Given this list of marker genes KCNK6, ELAVL1, ITGB2, ARAP2, COX17, PACSIN1, TARDBP, MIS18A, ORC2, PLAAT3, NCOA7, IL10RB, MCM5 (minichromosome maintenance complex component 5), LDLR, FAM98B, SLC4A7, SLFN12L, FASLG, SIMC1, TUBA1B, DUSP5, DYNLL2, PUS3 (NCBI Gene Id 83480), ATL3, IMPDH2, MED14 (NCBI Gene Id 9282), ACSL5, ITPR1, AR, TSPAN13, SERPINC1, BAZ1B, RCSD1, EGR3, FYN, RNF152, SNX9, PPP1R16B, MRPL15, POLE, HERC4, CYBA, ITK, TBC1D4, RPA2, IL6ST, TFRC, CSE1L, PHLDA1, RHOD (ras homolog family member D), ISOC1 (NCBI Gene Id 51015), EDC4, MND1, BEND3, RPIA, CSF2 (NCBI Gene Id 1437), OBI1, ARHGEF3, AGR3, TLK1, CD2AP, NEFH, EFHD2, PTER, CTSS, ARFGAP2, CRIM1, TCF20, TMEM131L, FAM111A, MINDY2, TESK2, MCM9, CDK1, TNFSF8, STARD4, SAMSN1, RAB34, NAA20, PENK, ERMP1, PTPRS, ADAM10, UBXN2A, PDCD4, DROSHA, IPO11, DTYMK, SMC6, MGAT4A, ZNF592, PLAGL1, POLR1F, NUCKS1, CENPA, PARP12, SLAMF6, ITIH5, PLXND1, SIK1, LANCL2, ACAT2, PTTG1, RFWD3, FOXK1, ATP11C, NAA50, QSER1, CD96 (CD96 molecule), MLH1, SLC23A2, ITGB1, NRP1, WDR75, WEE1, ZNF770, PLA1A, PSMB8, PHF14, RBBP7, HPS4, DAPL1, LIG1, EXO1, SEMA4C, ZSCAN21, SYTL2, ZNF280B, CDC20, LYPD6B, ST8SIA6, NCF1, PTS, SCIN, MSH6, KPNA2, CYC1, GAS2L3 (NCBI Gene Id 283431), TPST1, CD1D, FOXN3, NDUFAF4, RRM1, ELP2, GLIPR1 (NCBI Gene Id 11010), IPCEF1, IGFLR1, KLHL2 (NCBI Gene Id 11275), CAB39, HOMEZ, PTDSS1 (phosphatidylserine synthase 1), APOBEC1, EOMES, ANKRD44, VAV3, XPO7, RBMXL1, MTRR, SLC19A1, SQLE, SHTN1, CMTM7, ENO3, TRAF5, PRKAG2, CSN2, C1QTNF12 (C1q and TNF related 12), ATXN7L3B, TEX10, CHD3, CD83, CCT3, GPR34, CNOT6, KNOP1, CCN3, CD48, IRAG2, IFI27L2, SERPINB9, P2RX7, RDH11, LCP2, SERPINE2, MBNL3, SCD, ADCY6, CASP3, LIN7A, RAB3IP, MTDH, TTC27, RASGRP1, SH2D1A, MAP3K8, DNMT3B, CAPN3, TBRG4, ARL15, CYP51A1, here is a description of the gene set: from publication Lee Y, Awasthi A, Yosef N, Quintana FJ, Xiao S, Peters A, Wu C, Kleinewietfeld M, Kunder S, Hafler DA, Sobel RA, Regev A, Kuchroo VK (PMID 22961052) species: Homo sapiens TGF-beta3 produced by developing Th17 cells induces highly pathogenic T cells that are functionally and molecularly distinct from TGF-beta1-induced Th17 cells. The microarray data represent a distinct molecular signature for pathogenic versus non-pathogenic Th17 cells. Human Gene Set: GSE39820_CTRL_VS_IL1B_IL6_IL23A_CD4_TCELL_UP Genes up-regulated in comparison of untreated CD4 T cells versus those treated witl IL1B, IL6 and IL23A.